Given this list of marker genes Klf6, Hspa1a, Jun, Btg2, Uba52, Dnajb1, Junb, Hspa1b, Tsc22d3, Fos, here is a description of the gene set: Genes negatively differentially expressed in cell type: CD4+ T cell upon treatment with cytokine: IL-Y in mouse lymph nodes in vivo. species: Mus musculus Cytokines mediate cell-cell communication in the immune system and represent important therapeutic targets. A myriad of studies have highlighted their central role in immune function, yet we lack a global view of the cellular responses of each immune cell type to each cytokine. To address this gap, the authors created the Immune Dictionary, a compendium of single-cell transcriptomic profiles of more than 17 immune cell types in response to each of 86 cytokines (>1,400 cytokine-cell type combinations) in mouse lymph nodes in vivo. A cytokine-centric view of the dictionary revealed that most cytokines induce highly cell-type-specific responses. For example, the inflammatory cytokine interleukin-1β induces distinct gene programmes in almost every cell type. A cell-type-centric view of the dictionary identified more than 66 cytokine-driven cellular polarization states across immune cell types, including previously uncharacterized states such as an interleukin-18-induced polyfunctional natural killer cell state. Mouse Gene Set: CUI_T_CELL_CD4_IL_Y_RESPONSE_DN from publication Cui A, Huang T, Li S, Ma A, Pérez JL, Sander C, Keskin DB, Wu CJ, Fraenkel E, Hacohen N (PMID 38057668)